The following is a description of a gene set: Marker genes curated from the annotated cluster as represented in the Descartes Human Gene Expression During Development database. species: Homo sapiens Human Gene Set: DESCARTES_FETAL_CEREBELLUM_PURKINJE_NEURONS The gene expression program underlying the specification of human cell types is of fundamental interest. The study authors generated human cell atlases of gene expression and chromatin accessibility in fetal tissues. For gene expression, the study authors applied three-level combinatorial indexing to >110 samples representing 15 organs, ultimately profiling ~4 million single cells. The study authors leveraged the literature and other atlases to identify and annotate hundreds of cell types and subtypes, both within and across tissues. Our analyses focused on organ-specific specializations of broadly distributed cell types (such as blood, endothelial, and epithelial), sites of fetal erythropoiesis (which notably included the adrenal gland), and integration with mouse developmental atlases (such as conserved specification of blood cells). These data represent a rich resource for the exploration of in vivo human gene expression in diverse tissues and cell types. from publication Cao J, O'Day DR, Pliner HA, Kingsley PD, Deng M, Daza RM, Zager MA, Aldinger KA, Blecher-Gonen R, Zhang F, Spielmann M, Palis J, Doherty D, Steemers FJ, Glass IA, Trapnell C, Shendure J (PMID 33184181), and this is the list of marker genes: HS3ST2, LINC01440, SHH, GPR39, LINC02753, API5P2 (apoptosis inhibitor 5 pseudogene 2), LOXL1-AS1, COL6A5, FAM153CP (NCBI Gene Id 653316), TAF4B, ITPR1-DT, RN7SL132P, FOXP4-AS1, FGF19 (fibroblast growth factor 19), LINC02319, MIR4527HG, CORIN, ATP2B2-IT1, ST13P20, RPL3P13, LINC01630, LINC00559, ARHGEF33, CYP4Z2P, PPP1R2P5, ESRRB, RPS20P5, LINC01047, IFNG-AS1, PRMT8, IL1RAPL2, ITPR1 (inositol 1,4,5-trisphosphate receptor type 1), TRIM60P13, PENK-AS1, LINC01640, KLF5, LINC02008, HSPA12A, ARG1, SLC1A6 (NCBI Gene Id 6511), WNT16, VIT, CDS1, ENSG00000261090, SLCO4C1, AP1M2, ENPP7P8, LINC00299, LINC02336, ABCA17P (ATP binding cassette subfamily A member 17, pseudogene), ANKRD33B, DCDC2C, AIPL1, EGOT, MED28P8, LINC02102, SEMA3E, TDRD5, FOXP2, ENSG00000254746, POLR2DP2, RPS26P15, METTL21C, POSTN, ANO1, PDE11A, ATP2B2-IT2, COL6A6, GNAT3, LINC01257, NDNF, SKOR2, DAB1, CA8, FGF3, COL24A1, ESRP1, LINC01539, GPC3, NPSR1, CALB1, PTGER3, RORA